The following is a description of a gene set: A process in which a protein is transported to, or maintained in, a location within the external part of the cell wall and/or plasma membrane. species: Homo sapiens Human Gene Set: GOBP_PROTEIN_LOCALIZATION_TO_CELL_SURFACE, and this is the list of marker genes: PICALM, MAP1A, HSP90AB1, ABCA12, TM9SF4, AKT1, FCER1G, FGF7, KCNAB2, VCL, EGF, COMMD1, CTNNB1, PTPRU, RAB11B, FBLN5, ANK2, ANGPT1, FLNA, MIR520E, GPD1L, NLGN2, HFE, TOR1A, RIC3, VPS54, STX4, ASTN2, JAM3, GGA1, GBF1, TNF, CD177, FCN1, GPIHBP1, USP4, TYROBP, ARF6, CAV3, ACTN2, NEDD4L, RANGRF, SNX33, ABCA2, GGA2, MIR520B, GGA3, TAX1BP3, MESD, PRRT1 (NCBI Gene Id 80863), UNC50, FGF10 (NCBI Gene Id 2255), GPM6B, RAB11FIP5, EMP2, CD247, BDNF, GOPC (NCBI Gene Id 57120), STX3, LEPROT, AP3B1, EPHB2, ABCA7, ERBB4, PTPRK, TMEM35A, LRIG2 (NCBI Gene Id 9860), RAB11A